Given this list of marker genes LRSAM1, ERCC6L2-AS1, HIRA (histone cell cycle regulator), DMAP1, TCF3, POP4, POU2F1-DT, PRKRIP1, MVK, WFDC1, NUP107-DT (NUP107 divergent transcript), RAD1, C12orf43, U2AF1L4, RBM15-AS1, PABIR1, YEATS4, COPZ1, TOM1L2, IQCD, TMEM41A (transmembrane protein 41A), P4HA3, GRK4, PRPF31, TDP2, ABCF2, MRPL49, GPRIN2, ZFYVE1, AKAP8L, LINC00938, NR1H2 (nuclear receptor subfamily 1 group H member 2), SMIM7, TEPSIN, CANX, FAM220A, NDUFA7, DNAJC11, ANKHD1-EIF4EBP3, ATP5F1B, SLC25A44, PLOD3, NDUFAF1, SMC3, KCTD10, U2SURP, WDR53, AGPAT1, PPIL3, MAD2L1BP, TTC31, WDR4, PCID2, ALKBH3, GAN, PBX3, SSNA1, ALKBH5, AGBL5, CKLF, ERG28, CIITA, CHCHD3, OPA1, SRSF1, NAPG, CWC25, GATB, PER1, KLRC4, ACOX3, MRPL3, EFTUD2, PURB, VIPAS39, SLC35B1, HEXIM2-AS1, MAGOHB, TRMT1, NUP155, NBR1, RBAK-RBAKDN (NCBI Gene Id 100533952), TRUB2, UBXN6, GPATCH3, RPRD2, ABCA11P, DNAJB11, RECQL4, GTF2IRD1P1, GNL1, PHF12, TNFAIP1, DHDDS (NCBI Gene Id 79947), RAB3D, RPS29, KATNB1, SOX6, YJU2, ZC3H3, THAP7-AS1, NFE2L1, SATB1-AS1 (SATB1 antisense RNA 1), MAF1, RAB35, PSMD5, RPL23A, PPP2R1A, VCP (NCBI Gene Id 94731), DCTPP1, POLR1HASP, ZNF26, NGF-AS1, TMEM60, ANAPC2, TMEM160, EIF2S2, RFX1 (regulatory factor X1), CCDC90B, STX16-NPEPL1, WDR24, SAR1B, CSTPP1 (NCBI Gene Id 79096), SIRT2, FAM185A, PPIL4, VIRMA, CFAP298-TCP10L, PUF60, ZNF341-AS1, SNORD12C, SF3A3 (splicing factor 3a subunit 3), CCNA2 (cyclin A2), RPUSD2, TUT1, PSENEN, UBP1, MIR4727, WDR43, PROSER3, RPL7L1, CEP250, PPP3CB, CHMP4A, NDUFA2, TMA16, DNAJC18, NUDT5, HAGH, AP2M1, LSM7, KLHL20, NHLRC3, KIAA1143, ZNF654, RNU11, MTND4P24, BOLA1, AIRIM, LRRC27, RAD18, MOCS3, HSPB6, MRPL39, PIGT, C8orf33, SH3YL1, CHURC1, DNAAF10, DSTYK, ALKBH7, BMS1, CWC27, TRMT44 (NCBI Gene Id 80015), BPGM, SLX9, MIR4526, GTPBP10, METTL25B, TNRC6B, TIMM22, BLOC1S3, GTF2IP12, CCDC174, ANAPC5, EIF1AD, FAM91A1, GTF3A, RBAK, ACAD9, TMEM183A, CRTC2, ACO2, GTF2IP20, UNK, DDX42, MRPL9, IGHMBP2, GRAP2, SNORD42B, EFCAB7 (EF-hand calcium binding domain 7), RBM28, ZNF581, PPIP5K2, RNU6-231P, SNRNP27, MST1P2, USPL1, GOLGA3, BRCA1, TAS1R1, PFKM, EHMT1, CDC123, RN7SKP175, PRMT5-AS1, PHTF2, PET100 (NCBI Gene Id 554363), PROSER1, RNU6ATAC, ADAR, MAIP1, HNRNPH3, NUP54, STX5-DT, MAFK, PALB2, RPS26P28, RNVU1-31, CAPZA1, CNOT1, PSMB7, CDKAL1, FBXO22, COPB2-DT, CLPTM1L, RPS6KB2, GAR1-DT, NFKBIB, ZNF79, CUL4A, NDUFAF8, PTPN21, AP2B1, RBM42, LAMA1, RPIA, MAPKAPK5-AS1, RPS28, SREBF2, SNX1, H2AZ2, PDE4A, EIF4A1, AASDH, RTEL1, VPS50, ENSG00000275765, PRCC, ANKRD26, BUB1B, HMGXB3, MARCHF6, HMGB1, HNRNPA0, HSPA6, ZNF721, TIMM9, MAGOH, B4GALT5, FLJ30679, UBE3B, SPNS1, SPAG8, CENPL, ATP5MF, PEX13, ST3GAL2, VCPIP1, TK2, IFT74, GALK2, GPRC5D-AS1, LINC02642, LMAN2, MIR638, GATC, ANKRD11, BORCS8-MEF2B, POLR1H, MED23, XNDC1N, CFAP298, GANC, MIR4539, RCE1 (Ras converting CAAX endopeptidase 1), RANBP6, PEF1, TOMM6, IPO4, TPRA1, MIR1538, SPAG7, PRMT5, TMEM209, ZFP1, POLR2K, COPS4, SNX15, ZZZ3, CTNNA1, HBS1L, ATP5F1D, ENSG00000268129, RPL36, ZNF77, RHBDD3, PPWD1, EXOSC5 (exosome component 5), SPTLC1, NKAPD1, SAFB, MIR1289-1, TMEM87A, SNAI3-AS1, SELENOH, EVI5L, ARMC1, PNO1 (partner of NOB1 homolog), NUMB, HSPE1, CSPP1, PWWP2A, LINC01409, CDC5L, GAR1, ISY1-RAB43, DCUN1D4, TSN, C17orf75, POLR2A, PRPF6, SRSF11, DNAJA3 (DnaJ heat shock protein family (Hsp40) member A3), NR1H3, INTS5, GCDH, CALCOCO1, ZNF165, PHF7, ZNF576, RPS13, MYPOP, FAM149B1 (NCBI Gene Id 317662), MRPL21 (mitochondrial ribosomal protein L21), DYNC1I2, KIF15, PTCD1, SLC39A3, PHF14, TOMM40, EIF2AK3, RRP15, MNAT1, CENPW, BANF1 (NCBI Gene Id 8815), TMTC3 (NCBI Gene Id 160418), COPS8, PRPF40B, ZC3HC1, DRC3, NUP160, LRCH4, AARSD1, TMEM106B, PPP4R3B-DT, INO80B, CPSF1 (NCBI Gene Id 29894), GTF2H4, SPON1, SLC25A11, HMBOX1, NFATC2IP (NCBI Gene Id 84901), ZBTB11, NUDT18, MRPL24, PMEL, STK19, WDR74, PCNX3, RPS6KB1, PABPN1, WASHC5, EID2B, ZDHHC6, MED1, BECN1, ZBTB6, EMC3, DPF2, LAMTOR5-AS1, MED24 (mediator complex subunit 24), MMACHC, MIR4279, NPM3, AP2S1, MYL11, RBM39, RPL37, FEM1A, DDX23, HSPE1-MOB4, TBC1D19, TRMT61B, MRPL16, NAIF1, METTL4, CXorf38, TICRR, CWF19L1, RNF139, TXNL1, MUL1, TARS2, DNAJB12 (NCBI Gene Id 54788), LYSMD1, ANKHD1-DT, GDF5, CRBN (cereblon), STX4, MRPL28, DYNLT2, CATSPERD, SRPRA, TMEM259, PSTK, EEF1A1P18, CDK5RAP1, ERGIC2, ZNF668, IFT80 (NCBI Gene Id 57560), XRCC2, DDX19A-DT, DCAKD, CMBL, ZNF17, ZGRF1, TPI1P2, ENPP3, FAM98B, CELF3, TSSC4, FLAD1, ZSWIM3, DNTTIP2, RBBP5, CCDC47, DNAJC21, MRPL44, ZNF143-AS1, TTC41P, APTX, USP54, PIPOX, TEFM, TMEM143, H3-3B, CCDC90B-AS1, POLDIP3, RNU6-418P, FARS2, LAMTOR5, UBE2I, MT-TL1, COPB2, COPS2, MRTO4, WDR11, JARID2, TCERG1, CHMP1B, DDX51, MED20, ACOT13, DCTN4, C11orf58, FMC1, ADPGK, INTS9, LAMP1, FAM222B, MRPL55 (mitochondrial ribosomal protein L55), PXMP2, PHB2 (prohibitin 2), DCAF7, RBM15, KMT5C, LSM5, SUGP2, LINC02926, MLST8, USP42, RANBP2, ANKRD16, VPS51, NUP107, BAP1, SMPD4, TMEM245, PPP4R3B, NCBP2AS2, SPEF2, NUDCD1, ILF3-DT, VANGL2, TACO1, USP19, BBS1, NAA38, SEC22B, SMC4, DHX33-DT, TMEM115 (NCBI Gene Id 11070), PRKACA (protein kinase cAMP-activated catalytic subunit alpha, NCBI Gene Id 5566), SKA3, SNORD59A, PSMC2, MRPL13, SSU72-AS1, NDUFS7, GNPTG, ZNF491 (NCBI Gene Id 126069), TNRC6B-DT, CFAP90, LMF2, DRG2, FAM162A (NCBI Gene Id 26355, family with sequence similarity 162 member A), TMEM199, CGGBP1, TRAPPC6A, TMEM9, FERRY3, CEP128, ERVK3-1, FRMD5, ZNF276, FAHD1, CENPP, C10orf88, TUBB4B, CCDC106, GTF2H1, ITGA7, FAM187A, TMEM205, NDUFB5, CTU2, RXRB, TATDN3, PHF5A, RPTOR, BYSL, DZANK1, EMC10, NLK, NFYB, WEE2-AS1 (NCBI Gene Id 285962), BOD1, KCTD5, HPS5, GARIN5A, CDC23, MMUT, UBLCP1, SECISBP2, LGALS3BP, HNRNPA1, CYTH2, COQ4, SRSF10, NGDN, MED6, NUBPL-DT, ROPN1L-AS1, CNOT3, NOL8, EEFSEC, NOP14, PIH1D2, MTMR9, VARS2, CXXC1, WDR75, OR5BJ1P, TUBD1, SAYSD1, ALG1, MRPL47, ADAP2, PDRG1, HAX1, ST7L, TMEM101, CAMTA1-DT, GK5, RAB11B-AS1, NIPSNAP2, FAM117A, ATG5, VIRMA-DT (VIRMA divergent transcript), RNU5B-1, ZNRD2-DT, STT3A, WDR36, MAPKAPK5, KBTBD6-DT, GTPBP2, INTS14, DDX55, ECD, FBXL19, ACAD11, TMEM242 (transmembrane protein 242), MRPL40, MTIF2, COPS7B, CDCA3, ACOT8, NDUFA3, GET3, POLG, MPHOSPH10, TAF11, PEF1-AS1, RNF121, CIDECP1, IDH3B, ZFAND2A-DT, PEX1, ZFYVE21, TPCN1, ZMPSTE24-DT, FBXL9P, ILF2, MCEE, TMEM208, INTS12, THAP7 (NCBI Gene Id 80764), TMEM138, ISOC2, PRR3, STX18, ACP1, MRPS17, PDCD7, SUPV3L1, NSMCE2, LINC02899, CCDC142, LZIC, MKRN2, TIMM17A, ABCF3, HNRNPC, POLA2, EMC4, ZNF564, ERCC5, RAD51AP1, DDX49, SMG7, AURKAIP1, SRRM5, IFT27, SLC27A5, SLC24A1, MKS1, FCF1, HACL1, HSPA5, PEMT, SYNGR4, SIVA1, ENSG00000261335, ZNF408, BRIX1, POM121, ZNF131, RPL9, METTL15, METTL9, SMG8, FAF1, VTI1A, TBCCD1, RLF, MOK, CCDC159, ENSG00000200191, CCHCR1, ZFAND2A (zinc finger AN1-type containing 2A), SLC25A42, UBA5, GATAD2A, C1orf74, BUD23, NDUFB6, PPRC1, PIGG, ZMAT2, HOXC5, PPP1R13L, STX18-AS1, ARHGEF2, B4GALT7, TMEM41B (NCBI Gene Id 440026), MIX23, CYB561D2, ARID3A, SMG6, NOL9, DAGLB, FBXO45, MTCO3P12, WDR31, DDX19A, GPI, USP30, DPM1, DNAJC30, SLC2A11, DUS2, SPG7, PSMC3, ZNF225-AS1, LIN52, DDX56, TMEM70, LAS1L, SFSWAP, ZNF490, CCDC97, SUMF1, KAT6B, DNAJC2, MRS2, ZNF141, RBM19, TSR3, IDH3B-DT, MAN2C1, KBTBD4, CAMKK2, RAB8A, TAX1BP3, LAMC1-AS1, CHTOP, ERCC6L2 (ERCC excision repair 6 like 2), ZNF143, ERP44, ISG20L2, PRMT5-DT, MIR4999 (NCBI Gene Id 100847049), C1D, SNX17, NME1-NME2, MIR4538, SETD3, PPM1B, ENY2, CORO7, ZNF791, RANBP10, BANP, DNM2, RNF166, EMG1, BUB3, SMARCAD1-DT, CIC, NFAT5, CHRNB1, TOMM22-DT, LRPPRC (leucine rich pentatricopeptide repeat containing), MGAT5, ELP4, HMGB3P22, FAM98A, MTBP, ACP2, NSUN2, LRP3, SMARCAD1, HELQ, FMC1-LUC7L2, ANKHD1, KAT7, NF2 (NCBI Gene Id 654093), MAP2K7, ALG10B, AK2, KANSL1, TMEM18, RALGAPA1, MRPL20, PCLAF, LARS1, PIDD1, RNU6-92P, NKAPP1, AP3S1, RNU5E-1, SCFD2, ADPRHL1, VPS52, LINC02098, GTPBP3, AGBL5-AS1, FZD1, CACTIN, NUF2, NSL1, CMTM3, POLR1G, ATP5PD, SLC35A4, MRPS31, NCBP2, CTNNA1-AS1, NDUFB3, CEP290, ZNFX1, AAAS, RPL12, TIGD6, CCDC59, STK32C, CHMP4B, FBXO24, ZFYVE28, LRRC40, ATAD3B, ARHGAP1, RGS5, SPC24, ZNF646, TFPT, GLOD4, TRIP10, RNF139-DT, WDR83OS, TXNL4B, RRM1, EEF1D, DNAJC8, BCKDHA, IARS1, DDX41 (NCBI Gene Id 96647), PIK3R4, SPPL2B, SEPTIN7P2, ENSA, STMN3, RNVU1-14, PRORP, MED18, CCDC86, DCP1A, STX16, SAMHD1, TMEM141, ZKSCAN4, PRKAR1A, AMN1, NUP214, ING3, GFM2, ALDH6A1, G3BP1, TTLL5, RPL31, TMEM128, NDC1 (NDC1 transmembrane nucleoporin), TRUB1, FBXO15, TMEM38A, IPO11, PSME3, GIN1, YJU2B, HEXA, RPL18, AHCYL2, RNU6-2, CCDC12, ERAL1, ZBTB17, HNRNPL, HDGFL2, WNT2B, INO80B-WBP1, ENSG00000232995, CDCA8, ZNF12, COQ9 (coenzyme Q9), PMS2CL, ROPN1L, NUDT13, CCNK, GTF3C3, LINC01547, CKLF-CMTM1, CDADC1, NOC4L, NMT1, TARS1, XAB2, WDR70, MTND5P11, PTPN23-DT, CCNT1, PMS2P3 (PMS1 homolog 2, mismatch repair system component pseudogene 3), EEF1A1P23, OXNAD1 (NCBI Gene Id 92106), SLC39A7, HEXA-AS1, ZNF84, ERH (ERH mRNA splicing and mitosis factor), TMEM43, NDUFC2, MTHFSD, MZT2B, SLC25A28-DT, NIF3L1, WBP11, KCTD2, TIMM21, ENSG00000232876, RPL5, COMMD1, POLR3E, CCT4, INVS, AP5Z1, TIMM29, SNRPC, UBR1, PDZD2, PXMP4, DHX38, NDOR1, NUBPL, RUVBL1, HSP90B1, PPP6R1, KAT6A, EMC3-AS1, POLE, WDR83, LINC02868, CROCCP2, CDK12, REXO4, NPRL2, TIGD5, NDUFA12, NT5C2, POMGNT1, PLAA, RECQL5, GSTCD, PIGL, DCAF11, SKP2, CD69, PAK1IP1, VPS9D1, SEPTIN7P14, KHSRP, NOP16, EIF3E, NSA2, SLC7A6OS, JMJD4, KMT2A, PRMT7, ILF3, KMT2D, CCT6B, RPLP2, LIAS, MIR4757, FANCD2, C6orf52, MT-RNR1, USP48, RAD9A, KLRC2, RNF167, SEPTIN7P13, NME1, RPS6, SLC35E1, PPP2R3C, STOML2, BTBD10, SNHG10, MRPS18C, PCYT1A, IFT56, C12orf60, JRK, IFTAP, ZNF561-AS1, LRRC14, CDK11A, NDUFAB1, NDUFAF4P1, UNC45A, TMED2, SEC13, PUS10, DPH3, DHX33 (NCBI Gene Id 56919, DEAH-box helicase 33), KRR1, STRIP1, AP2A1 (adaptor related protein complex 2 subunit alpha 1), CFAP99, SUPT7L, EWSR1, RNF5, IFRD2, MVD, TSFM, SSU72, ITGAE, UTP3, LARP7, HSPD1, CCDC191, NVL, CCAR2, KIAA0232, AREL1, TYW5, COX16, NAGPA, GPR108, ZNF614, CIAPIN1, IFT20, RGS1 (regulator of G protein signaling 1), PPP1R3F (protein phosphatase 1 regulatory subunit 3F), ANKFY1, CENPQ, CENPA, PRPF18, HSPA5-DT, ZNF263, SRFBP1, DPP9, CCDC77 (coiled-coil domain containing 77), NAT10, MTOR, LSG1, SELP, PRDX1, ISY1, MPDU1-AS1, NDC80, XRCC5, LINC01719, KLRC4-KLRK1, SCNM1, HASPIN, AP3S2, QTRT2, FAU, METTL25, MIR4479, RPS7, BRF2, TMEM39A, MT-TF, ZNF830, ABHD2, EXOC8, HIKESHI, TMEM222, SRRD, RAB11B, ATP6V1C1, HBP1, BORCS8, HDGF, PRRG2, ELOC, TPP1, COASY, UBQLN1-AS1 (NCBI Gene Id 105376114), RAB40C, GPAM, EIF3F, ATP5MF-PTCD1 (ATP5MF-PTCD1 readthrough), ADAT2, NEMP1, GLRX5, MRPL53, GTPBP4, QRICH1, NUP153, TTC1, ADPRS, ZFAS1, CNPY2, ZNRD2 (zinc ribbon domain containing 2), FBXW9, KDM5A, AHSA1, FBXL19-AS1, VWA5A, POLDIP2, TRIP4, ABT1, RPL24, RPL17-C18orf32, SF3B5, JUP, MT-ND1, TSKU (NCBI Gene Id 25987), FAM228B, PDCD6IP, TSPAN31, ANAPC15, MED9, ATG12, NBR2, MDH1, WDPCP, EMC1, NFIC, TNPO3, TMEM203, CDKN2C, ERMARD, NFX1, VPS33A, SP1, JARID2-DT (NCBI Gene Id 118597839), SLC39A9, PWP1, PREB, WDR11-DT, CHCHD4, KRTCAP2, CHURC1-FNTB, EIF2AK3-DT, RBM23, CCDC103, HPS4, ZNF687-AS1, OSCAR, ZNF268, OGFOD2, XRCC3, LDLRAD4, ARRDC1-AS1, POLG-DT, ZNF580, GHITM, MRPL48, POM121C, OAZ3, EEF1A1, PSMF1, ALG10, GTF2B, RPS11, N6AMT1, RNU7-27P, ZBTB45, VPS25, NFE2L1-DT, E2F4, DCAF15, MSMO1, COMMD2, MPV17L2, COPE, TSNAXIP1, MITD1, MIA3, NOSIP, MAP3K11, SPRTN, CCDC163, HEXIM2 (NCBI Gene Id 124790), RPS18, TOP3B, KBTBD6, NDUFS3 (NCBI Gene Id 4722), APBB3, MRPL30, TRIM46, NDUFC2-KCTD14, IRGQ, RTTN, GTF3C5, COPS8-DT, FSBP, YIPF2, WNK1, RAB35-AS1, LTN1, SENP1, SNAP47, IK, RAB5B, ZNF561, BLOC1S1, MRM3, RFX2, SF3B6, CENPK, NDUFV3, PSCA, SAP30BP, STAT3, SREK1IP1, TRAF2, RBM48, UQCC4, C12orf76, MRPL57, ZNHIT1, RTEL1-TNFRSF6B, AQR, TRIAP1, CLPB, MOB4, MAGOH-DT, MRPL2, KLC4, BMF, RPS26, MIR4507, LONP1, DARS2, C2orf49 (NCBI Gene Id 79074), GBF1, SLC25A28, RELA, INKA2, RAB30-DT, FDPS, TRMT2A, TXN2, MT-TP, ACSF3, MAP3K7, TBC1D10B, FOXRED1, MRPS31P5, ICE1, NUFIP1, MED27, MRPS23, TOMM22 (NCBI Gene Id 56993), SSBP1, IMMP1L, DXO, SEC11A, SHARPIN, ABCB8, UQCC1, GPALPP1, AAR2, ENSG00000200288, STIP1, PTPN23, DYNLT1, CREBBP, TMEM63C, H2AZ2-DT, NMNAT1, CYB5D1, MRPL4, PPP3CB-AS1, RANBP1, RNVU1-6, OGFOD1, CIAO2A, C7orf50 (chromosome 7 open reading frame 50), RFXANK, ABCB9, ZNF225, MCRS1, LENG1, PHLPP1, SNX12, RPL17, CFAP410, HYCC2, UQCC6, EIF2B4, FAM76A, TCF19, VTRNA1-3, MRPL1, ITGB3BP, RPL23, FRYL, FBH1, PDCD6, LINC02145, SNORD58B, RN7SL1, SIN3A, RAD23A, PAGR1, NOL12, MIS18A, NUDT21, EIF2D, EXOSC9 (exosome component 9), ZMPSTE24, TBL3, NUBP2, DYRK1B, POLR1F, ATP13A4, RAD21, SP2, SPHK2, SMARCD3, DENR, NCAPH2, PRMT1, PSMC4, HNRNPUL1, ARMC6, SNORA21, SAFB2, KIAA0586, SLC33A1, MRPS31P4, TMEM242-DT, PEX3, MTERF4, EMC6, EXOSC3, BTD, PDE12, POU2F1, ZNF687, RAB30, HMGCR, COPS5, RAB18, ZBTB3, SMG7-AS1, CAMTA1, SPSB3, SLC25A25, DCTN5, HDAC6, TOR1AIP1, ZNF84-DT, LYRM4, GTF2IP13, SPTLC2, TSKU-AS1, SLC4A1AP, PDE6D, LIPE-AS1, POLR3F, UBQLN1, here is a description of the gene set: species: Homo sapiens Human Gene Set: SUPT20H_TARGET_GENES from publication Yevshin I, Sharipov R, Kolmykov S, Kondrakhin Y, Kolpakov F (PMID 30445619) Genes containing one or more binding sites for (SUPT20H) in their promoter regions (TSS -1000,+100 bp) as identified by GTRD version 20.06 ChIP-seq harmonization.